Given this list of marker genes Fhod3, Prdm8, Cdh4, Nav2, Tub, Cap2, Pcdh18, Tbr1, Cemip, Ppp2r1b, Dpy19l1, here is a description of the gene set: Genes expressed at higher levels in rostral regions beginning in the intermediate zone, in some cases extending into the cortical plate of embryonic day 14.5 mouse cortex. Mouse Gene Set: HEVNER_CORTEX_ROSTRAL_INTERMEDIATE_ZONE species: Mus musculus from publication Bedogni F, Hevner RF (PMID 34321999)